The following is a description of a gene set: Nitric Oxide (NO) inhibits smooth muscle cell proliferation and migration, oxidation of low-density lipoproteins, and platelet aggregation and adhesion. It can stimulate vasodilatation of the endothelium, disaggregation of preformed platelet aggregates and inhibits activated platelet recruitment to the aggregate. NO is synthesized from L-arginine by a family of isoformic enzymes known as nitric oxide synthase (NOS). Three isoforms, namely endothelial, neuronal, and inducible NOS (eNOS, nNOS, and iNOS, respectively), have been identified. The eNOS isoform is found in the endothelium and platelets. NO regulation of cyclic guanosine-3,5-monophosphate (cGMP), via activation of soluble guanylate cyclase, is the principal mechanism of negative control over platelet activity. Defects in this control mechanism have been associated with platelet hyperaggregability and associated thrombosis. part of: Platelet homeostasis species: Homo sapiens Reactome Pathway: Nitric oxide stimulates guanylate cyclase, and this is the list of marker genes: NOS3, PRKG2, GUCY1B2, PDE2A (NCBI Gene Id 5138), ITPR1, KCNMA1, GUCY1A1, PDE1A, PDE10A, PDE9A, NOS1, KCNMB1, PRKG1, NOS2, GUCY1A2, PDE1B, IRAG1, PDE5A, GUCY1B1, KCNMB3, PDE11A, KCNMB4, KCNMB2